The following is a description of a gene set: Human Gene Set: HP_AMBLYOPIA Amblyopia studied in species Homo sapiens Reduced visual acuity that is uncorrectable by lenses in the absence of detectable anatomic defects in the eye or visual pathways., and this is the list of marker genes: CHN1, C1QBP, PDZD8, UFC1, ZEB1, NPHP4, COL25A1, CBS, MAFB, XYLT2, YME1L1, NF2, CRYBB1, OGT, DNMBP, NDP, ZFX, AP4B1, CDC42BPB, PUF60, COL11A1, ARHGEF2, CLCN6, DEPDC5, PIGN (NCBI Gene Id 23556), FOXL2, TUBB2B, NOG, ERF, COL9A3, VWA8, H4C3, COL9A1, KIF21A, MICU1, TEK, CYP1B1, NR2F1, MAP3K7, ADNP, TFE3, P4HTM (prolyl 4-hydroxylase, transmembrane), B3GAT3, COL8A2, PAX6, DPP6, ESAM, AHDC1, COL4A1, RRAS2, RIC1, SALL4, FZD4, VSX1, OCRL, AP4S1, LAMA1, WARS2, AP4M1, AP4E1, TBX1, GPR143, LRP5, PRR12, NDUFB11, MLXIPL, PRSS56, FLNA, AP1G1, SMCHD1, ELP4, CHST3, ADAMTSL4, PITX2, FGFR2, CRYAA, POLR3GL, HPS6, CRYGC, KAT6A, ATOH7, SOBP, WAC, RORA, FGFR3, H1-4, TWIST1, KIF11, KMT2D, GRHL2, TRIO, TUBA1A, MYOC, OVOL2, WDR26, TASP1, EPRS1, LTBP2, KCNN2, SMO, PHOX2A, DYRK1A, AFF4, MED12, SF3B2, LMBRD2 (LMBR1 domain containing 2), ELN, SCN8A, HDAC4, TUBB3, ZMIZ1, LIM2, COX7B, TANGO2, FBN1, MED25, HCCS, NFIX, COL9A2